Given this list of marker genes TAMM41, NDUFS4, CA5A, MPV17, SUCLG1, BCS1L, MT-TK, LIPT1, LDHD, MT-TL1, MT-ND2, MT-ATP6, GATM, MT-TV, TRMU, LYRM4, MT-ND1, MT-ND3, NDUFB10, SDHD, ATPAF2, MT-ND6, NFU1, NFS1, FBXL4, SCO2, MT-ND5, PET117, MT-ND4, TEFM (NCBI Gene Id 79736), NDUFA9, SLC25A21, MT-TW, PDP1, TMEM126B, here is a description of the gene set: Lacticaciduria Human Gene Set: HP_LACTICACIDURIA An increased concentration of lactic acid in the urine. studied in species Homo sapiens